The following is a description of a gene set: The process whose specific outcome is the progression of the skin epidermis over time, from its formation to the mature structure. species: Homo sapiens Human Gene Set: GOBP_SKIN_EPIDERMIS_DEVELOPMENT, and this is the list of marker genes: IGFBP5 (NCBI Gene Id 3488), SMO, FLG2, SRF, IL18, ALOXE3, LDB2 (LIM domain binding 2), KRT17, KPRP, NSDHL, HDAC1, KRT1, APCDD1, CLDN4, FZD3, DKK4, ATP7A, GATA6, TP63, LSR, EXT1, FOXN1, ALX4, FOXQ1, ACVR1B, SMAD4, RBPJ, ELOVL1, GORAB, NGFR, CD109, LHX2, DKK1, ALOX12B, ALOX12, PLA2G10, WNT10B, ABCA12, DSG4, GLI2, EDA, KLF4, SOX9 (NCBI Gene Id 6662), WNT10A, DNASE1L2, FZD6, LDB1, HDAC2, GRHL3, TMEM79, HOXC13 (homeobox C13), FST, FGFR2, CYSRT1, KRT84, PUM2, ZMPSTE24, RELA, AP3B1, CTNNB1, FUZ, COL6A1, NAGLU, NSUN2, GBA1, GNAS, PDGFA, SFN, MSX2, GAL, FLG, BCL2, NF1, KRT27, STMN1, SOSTDC1, NUMA1, FERMT1, SHH, VANGL2, DSC1, TFAP2C, NOM1, MYSM1, TNFRSF19, SNAI1, FA2H, NOTCH1, ZNF750, FOXI3 (forkhead box I3), HDAC3, WNT5A, DLL1, DLX3, INHBA, KRT71, PIAS4, TGFB2, SOX21, SOS1, KRT16, CYP26B1 (NCBI Gene Id 56603), STARD7, LGR5, INTU, TRPC4AP, PLEC, TGM3, KRT25, CDH3, GRHL1, FGF10, UGCG, ERCC2, LAMA5, FGF7, HRNR, KDF1, LRP4, MET, SPINK5, EGFR (epidermal growth factor receptor), SAV1, LGR4, KRT28, SOX18, SLC39A7, EDAR, CLDN1, TRADD, PKP3, NFKBIZ, TNF, TMPRSS11F, ZDHHC21, FOXE1, HPSE